Given this list of marker genes ZNF239, JMJD6, PIGF, NDUFC1, KPTN, GSTT2, IDH2, PLXNB3, PRSS23, MAP2K6, NDUFB2, NUPR1, TMEM30A-DT, RAP1GAP2, MOV10, POC1A, CMPK1, POP1, STK16, ACTR3B, SLC48A1, BET1, SUV39H2, AKIP1, WDR45, SURF1, WEE1, CTNNBIP1, RPS6KA5, PON1, ALOXE3, CAMK2B, AGBL3, NICN1, PRKCSH, WNT9B, WASHC3, WRN, SELENOM, SIRT2, GINS4, DYNLT2B, RIT1, NAAA, PTPRG, NHP2, DHDH, PXYLP1, RUVBL1, RBMXL1, LZTR1, EMD, HAGHL, CEP135, NOBOX, CHCHD2, SPATS2, CIT, FAM90A13, DNAAF5, BORCS7 (NCBI Gene Id 119032), COMMD10, TMEM41B, SMTN, OTOS, ATN1, MIB2, KANK3, CSNK2B, CDR2, FNIP2, LSG1, PPP1R15B, SLC2A8, CEP76, PDIK1L, TFPI, STK11, F5 (coagulation factor V), ANGPTL4, MRPL19, GPC1, ARPC1A (actin related protein 2/3 complex subunit 1A), XBP1, NUDT9, MANBA, KCTD20, SNRPF, PGLS, YIF1A, DUSP16, RAB27B, TECPR1, ZNF141, PIGY, IL4R, TBC1D24, AKAP1, FHIP1B, SARS1, NDUFV2, TIMM23, ENPP4, MRPL55, ANP32B, UNC13C, YDJC, TAFA3, RBKS, ANKRD28, TIFAB, KLHL30, MAPKAPK2, SPO11, ITGB5, UGCG, TMEM126A, TNP2, GMPR2, CORO1C, MAP9, REEP4, RTL8B, RSL24D1, SPRY2, UBE2J2, BHLHE40, TMOD3, NKIRAS2 (NCBI Gene Id 55590), METTL26, C19orf38, HUS1, DCAF12, DCTD, TMEM86B, SEC24D, BAG5, GPR108 (G protein-coupled receptor 108), MRPL34 (NCBI Gene Id 65994), LRRC18, RPL24, SYNE2, PLCB2, SLC25A40, MED8, OLFM1, PLPBP, GSS (NCBI Gene Id 2937), COPS5, PTGES, DRAM2, SCFD2, C15orf39, TMEM63C (NCBI Gene Id 57156), UTP11, ABCB9, PSMA5, C6orf118, NSMCE1, MIB1 (MIB E3 ubiquitin protein ligase 1), HDGF, ARID5A, CDC123, FANCD2, VPS8, MTERF4, SMC5, GCAT, HRAS, MEMO1, SETD4, ATP5MK (ATP synthase membrane subunit k), STX8, ASIC1, CUZD1, TBRG4 (NCBI Gene Id 9238), PDK1, CHMP2A, RBM8A, THOC7, DHRS13, PIF1, RAD54B, RNF115, BIK, CTSF, VIPR1, HRC, LONRF3, PGC, BICD2, KARS1, CD69, ABT1, TMEM143, FAM216A, MIS18A, VPS37C, MRPS16, SOX5, here is a description of the gene set: species: Homo sapiens from publication Wei G, Wei L, Zhu J, Zang C, Hu-Li J, Yao Z, Cui K, Kanno Y, Roh TY, Watford WT, Schones DE, Peng W, Sun HW, Paul WE, O'Shea JJ, Zhao K (PMID 19144320) Human Gene Set: GSE14308_TH1_VS_NATURAL_TREG_UP Genes up-regulated in comparison of Th1 cells versus natural regulatory T cell (Treg). Multipotential naïve CD4+ T cells differentiate into distinct lineages including T helper 1 (Th1), Th2, Th17, and inducible T regulatory (iTreg) cells. The remarkable diversity of CD4+ T cells begs the question whether the observed changes reflect terminal differentiation with heritable epigenetic modifications or plasticity in T cell responses. We generated genome-wide histone H3 lysine 4 (H3K4) and lysine 27 (H3K27) trimethylation maps in naïve, Th1, Th2, Th17, iTreg, and natural (n)Treg cells. We found that although modifications of signature cytokine genes (Ifng, Il4, and Il17) partially conform to the expectation of lineage commitment, critical transcription factors such as Tbx21 exhibit a broad spectrum of epigenetic states, consistent with our demonstration of T-bet and IFN-gamma induction in nTreg cells. Our data suggest an epigenetic mechanism underlying the specificity and plasticity of effector and regulatory T cells and also provide a framework for understanding complexity of CD4+ T helper cell differentiation.